Given this list of marker genes FRAT1, CCND1, WNT10B, WNT5A, FZD5, WNT3, FZD1, WNT9B, FZD7, LRP6, AXIN2, WNT16, WNT5B, WNT1, FZD4, WNT10A, FZD9, LRP5, FRAT2, FZD3, GSK3B, DVL3, FZD6, WNT6, WNT8A, WNT2B, CTNNB1, WNT9A, WNT7A, MYC, TCF7L1, TCF7L2, WNT7B, LEF1, WNT2, FZD2, FZD8, WNT3A, WNT4, DVL1, APC, TCF7, DVL2, WNT8B, AXIN1, FZD10, here is a description of the gene set: species: Homo sapiens Pathway Definition from KEGG: WNT -> (FZD+LRP5/6) -> (DVL+FRAT) -| (GSK3B+AXIN+APC) -| CTNNB1 -> TCF/LEF => (MYC,CCND1) Human Gene Set: KEGG_MEDICUS_REFERENCE_WNT_SIGNALING_PATHWAY Wnt signaling pathway. Pathway ID: N00056. Pathway type: Reference. Pathway class: nt06505 WNT signaling.